Given this list of marker genes STAT3, PCYT1A, SLC37A4, MPV17, LIPA, PCK1, here is a description of the gene set: studied in species Homo sapiens Increased echogenicity of liver tissue on sonography, manifested as an increased amount of white on the screen of the sonography device. Human Gene Set: HP_INCREASED_HEPATIC_ECHOGENICITY Increased hepatic echogenicity